Given this list of marker genes NHERF1, GNAS, GRIA1 (glutamate ionotropic receptor AMPA type subunit 1), NEDD4, AKAP5, PDE4D, here is a description of the gene set: Human Gene Set: GOMF_BETA_2_ADRENERGIC_RECEPTOR_BINDING Binding to a beta-2 adrenergic receptor. species: Homo sapiens